Given this list of marker genes GATA6, PLAGL1, PTF1A, STAT3, BLK, CNOT1, PAX4, APPL1, PDX1, KCNJ11, INS, ABCC8, GCK, EIF2AK3, HNF1A, CEL, ZFP57, KLF11, NEUROD1, HYMAI, HNF4A, here is a description of the gene set: Neonatal insulin-dependent diabetes mellitus Human Gene Set: HP_NEONATAL_INSULIN_DEPENDENT_DIABETES_MELLITUS studied in species Homo sapiens